Given this list of marker genes IL2RB, STAT5B, GAB2, JAK1, IL4, GRB2, SOS1, IL2RG, CCND2, FASLG, ELF1 (NCBI Gene Id 1997), IL2, SHC1, SP1, PIK3CA, JAK3, BCL2L1, FOXP3, MYC, PIK3R1, LTA (NCBI Gene Id 4049), CCND3, PTPN11, STAT5A, LCK, BCL2, PRF1, IL2RA (interleukin 2 receptor subunit alpha), CCNA2, CDK6, here is a description of the gene set: IL2 signaling events mediated by STAT5 Human Gene Set: PID_IL2_STAT5_PATHWAY from publication Schaefer CF, Anthony K, Krupa S, Buchoff J, Day M, Hannay T, Buetow KH (PMID 18832364) species: Homo sapiens